Given this list of marker genes ERGIC2, PYGM, CPEB1, MYH1, G3BP2, IL15RA, CCNJ, TRIP12, ATP6V0B, ICOSLG, KDR, ADAMTSL5 (ADAMTS like 5), PPP1R17, GABPB1, PNPLA3, DHX58, STARD5, ASNS (NCBI Gene Id 440), IL23A, PSMC4 (proteasome 26S subunit, ATPase 4), TMEM229B, ITGA4, INPP1 (inositol polyphosphate-1-phosphatase), RNF17, IGSF8, CHST7 (carbohydrate sulfotransferase 7), UCN, FSCN1, VPS54, AHCTF1 (NCBI Gene Id 442770), CSPG4, PTGES, BFAR, DUSP16 (NCBI Gene Id 80824), HCN2, TSPYL1, USP27X, TUBA8, MECP2, CNOT4, SIX4, TMEM121B, CORO2A, CRISPLD1, PDK3, NECAP1, RNPC3, TNFRSF1A, SLFN12L, STAT2, PTH2R, C11orf68, NMD3, CD47, PNO1, METTL6, MECR, RAP2A, PLCL2, CACYBP, PAFAH1B2, LMO4, NUDT9, STXBP3, HERC2, PLAGL2, RALGDS (ral guanine nucleotide dissociation stimulator), GSAP, ABCC8, SLAMF8, CD81, DDX39A, NMUR1, HOMER1, ZNG1B, ANXA7, SPRY4, FAM50B, CD200, AGFG1, PHC2, GMPPB, NIPSNAP3A, PPP1R15A, AFG2A, MAPKAPK2, MRPL54, HAT1, DPF1, BLOC1S4, MITF, MORC3, ETS2, YBX3, RILPL1, USP15, CLK3 (NCBI Gene Id 1198), EIF2S2, SLC28A2, MMP14, N4BP1, PTPN11, OLR1, ANXA1, HSP90AA1, VCL, DSCAML1, PPP1R14D, PPP2R5A, PARP14, GPR3, ZC3H11A, WBP2, PLEKHA3, IRGM, TRIM26, ATP5F1B, DGAT2, BATF, ADRB1, CHIC2, GTPBP2, TIPARP, PSMA4, SFT2D2, TAP1, F11R, BNIP2, COL5A1, KARS1, KRI1, NLGN1, SIGLEC7, RBM43, DNTT, LINGO1, TMPRSS5, ITGB1, ACVR1, ZNFX1, ELAVL3 (ELAV like RNA binding protein 3), ATAD1, DHX15, BHLHE22, ENDOD1 (endonuclease domain containing 1), PRPF38A, MAFF, EIF3J, ZDHHC5, RNF126, TRA2B, NUP88, TMEM243, IGBP1, PRKRIP1, DHX38, CAVIN1, FNDC7, SOS1, CUEDC1, MFAP4, MAGEL2, FCAMR, NOMO1, XKR6, ATF3, STXBP1, CCL2, MACROH2A1, NUBP1, CBLN1, LRRC59, ILF3, ICOS (inducible T cell costimulator), AP1G1, PENK, MX1, RAB3IP (NCBI Gene Id 64325), NTSR2, CAPN6, EBNA1BP2, MMP7, RARS1, CEP164, RND3, MAGIX, TMEFF1, HPCA (NCBI Gene Id 3208), CCNL1, SHC1, CCDC167, ALDH18A1, FURIN, GBP2, SEC13, PKP4, SLC31A1, ZFAND3, KRT2, GALR3, here is a description of the gene set: mouse primary BMDCs were stimulated with tlr ligands and gene expression changes were profiled on Affymetrix arrays species: Homo sapiens Genes down-regulated in comparison of control dendritic cells (DC) at 6 h versus those stimulated with CpG DNA (TLR9 agonist) at 6 h. Human Gene Set: GSE17721_CTRL_VS_CPG_6H_BMDC_DN from publication Amit I, Garber M, Chevrier N, Leite AP, Donner Y, Eisenhaure T, Guttman M, Grenier JK, Li W, Zuk O, Schubert LA, Birditt B, Shay T, Goren A, Zhang X, Smith Z, Deering R, McDonald RC, Cabili M, Bernstein BE, Rinn JL, Meissner A, Root DE, Hacohen N, Regev A (PMID 19729616)